Given this list of marker genes GIMAP8, LGALS3, PDCD1, RIPK3, CCL5, ZC3H8, TSC22D3, BAX, BBC3, LYN, LGALS9, BCL10, BCL2L11, IL10, HSH2D, CD3G, TP53, PIP, CD74, HIF1A, KIFAP3, PERP, GPAM, CD274, FOXP1, IL7R, FADD, MIF, MIR17HG (miR-17-92a-1 cluster host gene), BCL11B, ADA, WNT5A, IDO1, FNIP1, CD27, BCL6, RORC, ST3GAL1, BTK, SLC46A2, JAK3, PRELID1, RAG1 (recombination activating 1), BIRC7, DOCK8, SLC39A10, BCL3 (NCBI Gene Id 602), PTCRA, ORMDL3, NOC2L, ADAM8, AURKB, IRS2, LGALS16, BCL2, IL2, P2RX7, ARG2, EFNA1, PRKD2, MYC, BMP4, TGFB2, PRKCQ, here is a description of the gene set: species: Homo sapiens Human Gene Set: GOBP_REGULATION_OF_LYMPHOCYTE_APOPTOTIC_PROCESS Any process that modulates the occurrence or rate of lymphocyte death by apoptotic process.